Given this list of marker genes Gm18292, Ooep, Gm3126, Gm35262, Gm8151, 4930562D21Rik, Gm19572, Gm35024, Gclc, Omt2b, Gm15896, Gm8116, Fbxo9, Aldoa-ps3, D430036J16Rik, Gm18863, Gsta13, Cd109, Timm29-ps1, Dppa5a, Gm9531, Cilk1, Gm39375 (predicted gene, 39375), Cox7a2, Cgas, Omt2a, Gm8087, Dppa5c, 4930429F24Rik, Gm34829, Gm46138, Gm10635, Gm17324, Gsta1, Gsta2, Filip1, Tmem30a, Mto1, Col12a1, Htr1b, Myo6, Impg1, Eef1a1, Gm35548, Gm27227, Gm23748, Gm23609, Gm3211, Gm19228, Dppa5b, Ddx43, Gm8125, Senp6, Aldoa-ps4, Gm24393, Gcm1, Gm22836, Gm46146, Gm8058, 4921509A06Rik, 1700063H06Rik, Gm39377, Gsta5, Slc17a5, Gsta4, Elovl5, Gm34654, Gm8074, Gm8131, Gm26907, Gm39380, 4930542C12Rik, C920006O11Rik, Gm8093, Mei4, here is a description of the gene set: Mouse Gene Set: chr9E1 species: Mus musculus